The following is a description of a gene set: studied in species Homo sapiens Human Gene Set: STAT5A_03 Genes having at least one occurrence of the motif NAWTTCYN in the regions spanning 4 kb centered on their transcription starting sites. This matches the STAT5A transcription factor binding site V$STAT5A_03 (v7.4 TRANSFAC)., and this is the list of marker genes: TMEM216, PSMA1, KCNJ13 (NCBI Gene Id 619535), ORAI3, RWDD3, MDP1, FN1, NUFIP2, TRPS1, TRAF3, S100A4, LRRC41, TNFRSF11B, SPMIP6 (NCBI Gene Id 84688), EBF2, PTK7, MARCKS, SAG, SUMO2, IL1RAPL1, COCH, MTMR11, SLF2, TINAGL1, PDE3B, POLR3C (RNA polymerase III subunit C), EPHA2, PHOX2B, PSMA6, BCL11A, LAMA3, TPM3, RCAN1, TUG1, LIX1L, HOXC10, ACTN1, GAREM1 (NCBI Gene Id 64762), PPP2R3A, LPXN, ST13P5, PIM1, SPEF1, MAP4K4, PRKCE, LINC01597, ASIC2, BMP5, ARRDC3, MYO3B, CD274, GTF2B, STRIP1, PRDM12, ZNF281, FGF11, CACNA2D3, LRP5, FST, FBXW7, LMO4, LBX1, PTCHD1, MNS1, PTTG2, WNT10A, CBL, USP40 (NCBI Gene Id 55230), GNL3LP1, USP48, PLXDC2, N4BP1, SLC25A28, OLFML3, H2AC20, FGF13, IKZF3, CFAP161, MIR137HG, TMC1, EP300, KCNH7, ERG28, PATL1, INPP5F, IRX3, BBX, AKAP1, PCDH17, UBE2E4P, ANO2, NPR3, FGR, C1orf43, POLE2, TIAL1, KCNJ16, ROBO3, PLEKHA1, ST13P4, ATP2A2, ZFAND3, LRRN3, KDM6A, NEUROD2, APH1A, H2BC21, LINC01138, CNOT2, DNASE2B, KITLG, DNASE1L3, PCYOX1, HSPG2, HOXC4, KCNA3, H2AC21, ITGA7, HPCA, SH2B3, MEX3B, LONRF3, GRIA3, LRATD2, TNNI3K, EPN3, RAB3GAP2, NFE2L2, LSM12, ZSCAN18, CLCA3P, STMN1, RBM12B, LCOR, HOXA4, SLITRK2, HOXA3, SV2A, PCDH8, LAMP5, OFCC1, ANGPT1, CCDC60, SVIL, SLC26A7, VANGL1, MTSS1 (NCBI Gene Id 9788), CREB5 (cAMP responsive element binding protein 5), VGLL3, CLRN1 (clarin 1), LRP1, FAIM2 (Fas apoptotic inhibitory molecule 2), GRID2, RBMS3, SHC1, GPR150, NSRP1, STIMATE, NEDD4L, MYL6B, GPC4, NPNT, UGDH, CADM2, STK33, UBAP2L, SPRED1, C2CD3, TM9SF3, ZNF385A, GSTT4, MYT1, BCAR3, S100A9, RARB, ITGA2, SCUBE3, CELF4, HMGN5 (high mobility group nucleosome binding domain 5), IL25, ECEL1, PELI2, EMCN, GABRG1, UQCRH, VIP, FLT1, BORCS6, DPYSL2, VEGFD, ZBTB18, PROSER1, TOB1, ALS2CL, TBCD, TGIF1, FBXO9, SETD7 (NCBI Gene Id 80854), IL36A, USP11, F9, NT5C3A, DLX5, CXADR, STC1, CNGB3, TAB2, HOXC6, ADAM23, NEO1, CUX1, ZMAT4, RNF115, CHST9, RPA3, DACH2, C1QTNF6, BCL6, KIZ, NFATC4, TCTN3 (tectonic family member 3), PAK4, LCK, VRK1, CHCHD3, HEPH, TUBA1A, JADE1, ZBTB20, THBS2, DIP2B, SATB1, TLE3, SLC35A2, DENND2C, ERLIN2, MINDY1, UBE2H, FLNC, HOXB6, ETV6, ID3, NR4A3, CADM1, SLITRK5, ZPBP2, KLHL13, GNB4, KCNN3, EFHD1, ZNF407, ODAPH, TLX3, LYPD1, BTG1, KCND3, TIE1, FOXA1, LPL, MAPK14, DCTN2, SNCAIP, STAT3, SF3B4, FLRT3, KLHL3, PHACTR3, ZKSCAN3, ECHDC2, DHRS3, C12orf50, TCF4, SCN2B, AMD1, FAM53C